The following is a description of a gene set: Human Gene Set: MIR4432 studied in species Homo sapiens from publication Chen Y, Wang X (PMID 31504780) Genes predicted to be targets of miRBase v22 microRNA hsa-miR-4432 in miRDB v6.0 with MirTarget v4 prediction scores > 80 (high confidence targets)., and this is the list of marker genes: LRRFIP1, TXNDC16, ANTXRL, RFPL1, SLC33A1, HTR1D, MON2, PCDH10, RAB5C, CPA6, BTBD8, RNF182, UBE2V1 (NCBI Gene Id 7335), NCBP2, CFAP65, EPM2AIP1, FAXC, TESK2, ELFN1, ZNF281, INPP5E, RAD54L2, PCYOX1L, H2AZ1, CDYL2, NHSL3, LPIN2, OLA1, OSBPL1A, PCDH7, PRKAR1A, PLAG1, MTX3, MFSD8, ZNF703, CCDC198, TMC5, SKIL, AKT2, ZBTB43, GABRP, KLHDC7A, SLC7A6, REEP1, WASHC2A, RFPL3, NOCT, UBE2E1, LMX1A, KCTD8, MDGA2, SOX6, NADK2, STAU2, ARSJ, AEBP2, SRRM1, CYCS, RSBN1L, HYKK, TBC1D19, ACSL1, SLC38A9, CCNI2, PIGR, GDF9, WASHC2C, XPO4, VAV3